Given this list of marker genes IL23R (NCBI Gene Id 94006), TNFRSF11A, GFM2, PMP2 (NCBI Gene Id 5375), ATP1A2, ARSA, ITPR1, KIF1A, PYCR2, BSCL2, FAS, CFAP410, HMBS, MLH1, MPO, MATR3 (matrin 3), PRKRA, STUB1, CACNA1G, SOD1, ATXN1, GLRX5 (NCBI Gene Id 51218), PI4KA, TREX1 (three prime repair exonuclease 1), ALDH18A1, FA2H, OPA1, DARS1, ERCC3, CAPN1, ATL1, SLC19A3 (NCBI Gene Id 80704), TAF15, HNRNPA1 (heterogeneous nuclear ribonucleoprotein A1), GPT2, UBTF, CLPB, SLC39A14, DPM3, TIMM8A, UBQLN2, NAGA, MTPAP, RNU7-1, CNP, DTYMK, FUS, HPDL, SLC33A1, PSEN1 (NCBI Gene Id 5663), CCT5, GTF2E2, PTEN, PLAU, KARS1, APP, VWA3B, CHMP2B, DCTN1, BICD2, RTN2, AARS1, FUCA1, COQ2, SLC44A1, PNPLA6, MT-ATP6, DDHD2 (NCBI Gene Id 23259), RNASEH2A, COL4A1, TBP, SDHAF1, SELENOI, HTRA1, HEXB, CPT1C, ANO10, NT5C2, AFG3L2, CHP1, PIK3CA, SYNE1, IREB2, ALS2, PRPS1 (phosphoribosyl pyrophosphate synthetase 1), LMNB1, NDUFS1, VAMP1, TANGO2, GLT8D1, ATXN2 (NCBI Gene Id 8095), HADHA, FIG4, TARS1, NDUFS2, SLC2A1, FARS2, DDC, B4GALNT1, MPZ, SIGMAR1, IFNGR1, HSPD1, LARGE1, PDGFB, PTRHD1, SLC25A15, NALCN, PFN1, AAAS, ACOX1 (acyl-CoA oxidase 1), DNMT1, FGF13, TBC1D24, PNPT1, LETM1, RORA (RAR related orphan receptor A), PIGT, BCAT2, TREM2 (NCBI Gene Id 54209), ERBB4, DAO, RNF113A, CHCHD10, KY, GALC, ADPRS, DNAJC6, SNX14, EPRS1, UGDH, DSTYK, HADHB, PON2, NEK1, MAN2B1, RNASEH1 (ribonuclease H1), PANK2, GTF2H5, ZFR, ATXN3, COQ8A, PNKP, NOP56, MEFV, ELOVL4, TSEN2, MYORG, TRMT5, TMEM63C, SPG7, ADGRG1, ABHD12, ADAR, FKRP, POLD1, GBA2, PIGA, SAMHD1, RNASEH2B, TAF2, RETREG1, ZFHX3, MAPT, SDHB (succinate dehydrogenase complex iron sulfur subunit B), VAPB, PDGFRB, HLA-B, RTTN, DNAJC3 (DnaJ heat shock protein family (Hsp40) member C3), TSEN15, TSPOAP1, ZFYVE26, TTBK2, DPYS, ACADS, CYP2U1, TYROBP, ERLIN2, SPTAN1, SDHA, VRK1, FBXO7, SAMD9L, POMT2, EIF2S3, POLR3A, ATP1A3, PODXL, PSAP, PPP2R2B, ABCD1, DMXL2, EIF2AK2, NDE1, MDH2, GRID2, ADD3, GJB1, PEX16, ATP7A, GLE1, SETX, CAMSAP1, SQSTM1, SNCA, POLR1A, LSM11, KCNC3, ATXN10, PLP1, PARS2, MSH6 (mutS homolog 6), SCN1A, PCYT2, SPG21, POMK, UBAP1, NDUFA4, LYRM7, KLRC4, JAM2, ATG5, SPG11, TLR4, PRNP, MT-TE, ALG13, ATM, IMPDH2, POMT1, CNTNAP1, CWF19L1, PRSS12, AP4S1, MECR, SLC1A3, ETHE1, UNC13A, NFASC, NUP62, UBAC2, POMGNT1, SOX10 (SRY-box transcription factor 10), THG1L, SLC2A3, MTFMT, TGFBR2, AP4B1, RFC1, STAT4 (signal transducer and activator of transcription 4), AP4E1, ANXA11, SLC1A2, MFN2, AIMP1, CTDP1, RNF170 (ring finger protein 170), C19orf12, KLC2, REEP1, KCNA1, CACNA1A, VPS13D, TH, CYP7B1, PEX7, ASPA, PPARGC1A, IL12A-AS1, KMT2B, CYP27A1, TGM6, BCAP31, OPTN, WASHC5, RNASEH2C, ERAP1, FTL, MCOLN1, BRAT1, ATXN7, KCNA4, VPS13C, OPA3, TTR, NUBPL, KIF5A, DDHD1, SYNGAP1, EPCAM, TBK1, PRPH, NEFL, TSEN54, EARS2, TOR1A, IBA57, PMS1, DKK1, SLC12A5, NAA60, TARDBP, BMPR1A, GFAP, AMPD2, POLE, CLDN11, PRICKLE1, COQ4, WWOX, IL10, C4A, GCH1, L2HGDH, CARS1, UFC1, PGAP1, LIG3, GAN, GBE1, AHDC1, FXN, SLC1A4, GJC2, BRCA2, HYCC1, RARS1, SLC6A1, ABCB7, VCP, RPS20, SLC9A7, VPS41, SPAST, IRF2BPL, PON3 (paraoxonase 3), DNM1L, SHMT2, MAG, POLR3B, SLC16A2, TTC19, NOS3, POLG, KRAS, SPART, AIFM1, FBXL4, ERCC2, ANG, KPNA3, ATP2B3 (NCBI Gene Id 492), CCR1, TTPA, CCNF, SEMA4A, TWNK, SLC20A2, MTRFR, NIPA1, SLC25A46, PIK3R5, SCN1B, PMP22, ARX, ALDH3A2, ATP6AP2, PHYH, CAMTA1, TACO1, POU4F1, PEX10, RUSC2, PLA2G6 (NCBI Gene Id 8398), AARS2, GRM1, RRM2B, ABHD16A, AP4M1, CTC1, UCHL1, ATXN8OS, TMEM63A, NDUFS4, TSEN34, MTTP (NCBI Gene Id 4547), ENSG00000288330, TPP1, NDUFS7, GMPPB, TFG, MUTYH, PET117, CHEK2, CAV1, ELOVL1, SYNJ1, COX20, DLAT, HTT, MPLKIP, NEFH, COA8, SACS, MSH2, CHD2, SLC6A3, SEPSECS, KDM5C, GRIA3, NDUFA13 (NADH:ubiquinone oxidoreductase subunit A13), IFIH1 (interferon induced with helicase C domain 1), PON1, MECP2, TBC1D20, KIF1C, SNORD118, SDHD (succinate dehydrogenase complex subunit D), APOE, PDYN, NFU1, DARS2, AP2M1, GM2A, NEXMIF (NCBI Gene Id 340533), PMS2, IRF4, NUP54, COQ7, IDUA, PLAA, MORC2, ERCC6, NR4A2, ATP13A2, PRKN, LRP12, TMEM106B, IL12A, DEGS1, ERLIN1, REEP2, EEF2, NKX6-2, CTSF, here is a description of the gene set: Human Gene Set: HP_ABNORMAL_SPINAL_CORD_PHYSIOLOGY studied in species Homo sapiens Abnormal spinal cord physiology